Given this list of marker genes EU599041, Lefty1, Aldh1a2 (NCBI Gene Id 19378), Halr1, Runx1, Slc10a3, Slc6a4, Tbx1, Rxrb, Epha3, Ltk, Map7, Drd2, Star (steroidogenic acute regulatory protein), Gsk3b, Ascl1, Pax2, Dkk1, Gata6, Cyp26b1, Add1, Igfbp2, Tfrc, Abca1, Dnaaf2, Hand2, Oxt, Tek, Adh1, Nanog, Yap1, Gjb3, Aqp1, Sp100, Klf4, Ankk1, Ctsh, Gata4, Ovca2, Rarg, Twf2, Cdkn2d, Tead2, Mir3099, Brinp1, Serpinf1, Tesc, Yes1, Htra2, Asxl1, Ret, Col1a1, Gdap1, Ptk2b, Phb2, Srebf1, Cd38, Creb1, Cyp26a1, Abl2, Ccl2, Mef2c, Lrat, Rbp4, Brinp3, Gjb2, Snw1 (SNW domain containing 1), Brinp2, Suz12, Rorb, Hoxa2, Clk2, Ncoa1, Scamp3, Osr1, T, Lep, Ndufa13, Tnf, Atm (ataxia telangiectasia mutated), Tie1, Rhox13 (NCBI Gene Id 73614), Hoxa1, Lyn, Tbx2, Rxra (retinoid X receptor alpha), Acer2, Meiosin (meiosis initiator), Tnc, Sox9, Phc1 (polyhomeotic 1), Igf2r, Aqp3, Ptch1, Pou5f1, Rbp1, Krt13, Sox2, Tmem161a, Ptk7, Rara, Pck1, Gja1, Mest, Bmp6, Triml2, Rpl36al, Mmp2, Synj1, Stra8, Ptk6, Tescl (tescalcin-like), Hsd17b2, Tead1, Gdap2, here is a description of the gene set: Mouse Gene Set: GOBP_RESPONSE_TO_RETINOIC_ACID Any process that results in a change in state or activity of a cell or an organism (in terms of movement, secretion, enzyme production, gene expression, etc.) as a result of a retinoic acid stimulus. studied in species Mus musculus